The following is a description of a gene set: species: Mus musculus from publication Tseng YH, Butte AJ, Kokkotou E, Yechoor VK, Taniguchi CM, Kriauciunas KM, Cypess AM, Niinobe M, Yoshikawa K, Patti ME, Kahn CR (PMID 15895078) Up-regulated in brown preadipocytes with IRS1 knockout vs wild type controls; the knockouts have severe defects in adipocyte differentiation. The insulin/IGF-1 (insulin-like growth factor 1) signalling pathway promotes adipocyte differentiation via complex signalling networks. Here, using microarray analysis of brown preadipocytes that are derived from wild-type and insulin receptor substrate (Irs) knockout animals that exhibit progressively impaired differentiation, we define genes/expressed-sequence tags whose expression in preadipocytes correlates with the ultimate ability of the cells to differentiate. Many of these genes, including preadipocyte factor-1 (Pref-1) and multiple members of the Wnt signalling pathway, are related to early adipogenic events. Necdin is also markedly increased in Irs knockout cells that cannot differentiate, and knockdown of necdin restores brown adipogenesis with downregulation of Pref-1 and Wnt10a expression. Insulin receptor substrate proteins regulate a necdin-E2F4 interaction that represses peroxisome-proliferator-activated receptor gamma (PPARgamma) transcription via a cyclic AMP response element binding protein (CREB)-dependent pathway. Together these define a key signalling network that is involved in brown preadipocyte determination. Mouse Gene Set: TSENG_IRS1_TARGETS_UP, and this is the list of marker genes: Ceacam10 (NCBI Gene Id 26366), Nupr1, Tes, Sdc2, Grb2, Tcf7, Fhl1, Hspb2, Arxes2, Serping1, Iars1, Ccn4, Cpxm1, 1810009A15Rik, Ly6f, Siglec1, Mcpt4, Aopep, Rcl1, 4833445I07Rik, Actn4, Ptprf (protein tyrosine phosphatase receptor type F), Dctn5, Ccz1, Klra4, Arf3, Zdhhc6, Sqle, Actr3, Tnfaip2, Nr2f1, Farsb, Dbn1, Maip1, Apcdd1, B4galnt1 (NCBI Gene Id 71257), Bmp6 (bone morphogenetic protein 6), Mapk12, Ch25h, Lama4, Acly, Fap, Xrcc6, Glrb (glycine receptor, beta subunit), Nmt1, Rnf6, Dbnl, Fen1, Gas5, Mthfd2, Gtf2ird2, Dlk1 (NCBI Gene Id 13386), Gm33887, Pclaf, Bub1, Hspa4, Emc6, Asns, Cars1, Ndn, Col7a1, Adora2b, St13, Agtr2, Ddx47, Trib3, Rnf227, Or2n1e, Ddit3, Fbn2, Crabp2, Mef2c, Ddx18, Pag1, Rhou, Gbp2b, Prss23, Ldlr, Qng1, Cops5, Nop56 (NCBI Gene Id 67134), Fermt2, Tmx2, Zftraf1, Nsun2, Kcnu1, Srpx, Mgp, Yars1, Wnt5a, Nars1 (asparaginyl-tRNA synthetase 1), Sf3a1, Bpgm, Nde1, Cd24a, Tenm3, C1qtnf3, Rufy1, Nnat, Rpl39l, Ppih, Cdkn2b, Hspa9, Igf1, Pdgfa (NCBI Gene Id 18590), Nherf1, Gjb3, Spp1, Mid1ip1, Tshb, Phb1, Slc35c2, Arx, Tmem97, Mybl2, Zfp422, Pcyt2, Hoxd8 (homeobox D8), Crygd, Wnt10a, Efnb2, Slc3a2, Uck2